Given this list of marker genes Esrrb, Brms1, Smarcd1, Brd9, Yap1, Actl6b, Rest, Hdac2, Ing1, Kdm2b, Zfp322a, Bcl7a, Arid1a, Lbh, Smarcc1, Dpf2, Sin3a, Actl6a, Tead3, Bcl7b, Smarca4, Arid4b, Phf10, Sap30, Suds3, Sap30l, Tet1, Tead1, Smarcb1, Dsg2, Rbbp4, Sinhcaf, Tead4, Ss18, Sap130, Brms1l, Ing2, Hdac1, Smarca2, Bicral, Smarce1, Bicra (NCBI Gene Id 546025), Actb, Arid4a, Prdm14, Bcl7c, Ogt, Rbbp7, Sirt6, Trp63, Ncoa3 (nuclear receptor coactivator 3), here is a description of the gene set: Mouse Gene Set: GOBP_POSITIVE_REGULATION_OF_STEM_CELL_POPULATION_MAINTENANCE Any process that activates or increases the frequency, rate or extent of stem cell population maintenance. species: Mus musculus